The following is a description of a gene set: An endoplasmic reticulum part at which COPII-coated vesicles are produced. Mouse Gene Set: GOCC_ENDOPLASMIC_RETICULUM_EXIT_SITE studied in species Mus musculus, and this is the list of marker genes: H2-Q1, H2-Q4, Sec16b, Apob, Sec31b, H2-D1, Tfg, Sec24d, H2-Q7, Mia3, Pdcd6, Lrrk2, Sar1b, Yipf5, Preb, Mia2, Tmed5, Mppe1 (metallophosphoesterase 1), Sec24a, H2-Q2, Sec23a, Sar1a, H2-Q6, Sec23ip, Sec16a, H2-Q10, Plpp3, Pdcd6ip, Sec24b, H2-K1, Sec23b, Sec31a, Sec24c, Surf4